The following is a description of a gene set: This event has been computationally inferred from an event that has been demonstrated in another species.<p>The inference is based on the homology mapping from PANTHER. Briefly, reactions for which all involved PhysicalEntities (in input, output and catalyst) have a mapped orthologue/paralogue (for complexes at least 75% of components must have a mapping) are inferred to the other species. studied in species Mus musculus electronically inferred by orthology from the curated human pathway part of: Biosynthesis of specialized proresolving mediators (SPMs) Reactome Pathway: Biosynthesis of electrophilic ω-3 PUFA oxo-derivatives, and this is the list of marker genes: Ptgs2